The following is a description of a gene set: Human Gene Set: GOMF_STRUCTURAL_CONSTITUENT_OF_MYELIN_SHEATH studied in species Homo sapiens The action of a molecule that contributes to the structural integrity of the myelin sheath of a nerve., and this is the list of marker genes: MAL2, CMTM8 (CKLF like MARVEL transmembrane domain containing 8), PLP1, GPM6B, PLLP, NCMAP, MALL, MAL, MARVELD1, MOBP, MBP